The following is a description of a gene set: Human Gene Set: GOBP_NEGATIVE_REGULATION_OF_VERY_LOW_DENSITY_LIPOPROTEIN_PARTICLE_REMODELING Any process that decreases the rate, frequency or extent of very-low-density lipoprotein particle remodeling. Very-low-density lipoprotein particle remodeling is the acquisition, loss or modification of a protein or lipid within a very-low-density lipoprotein particle, including the hydrolysis of triglyceride by hepatic lipase or lipoprotein lipase and the subsequent loss of free fatty acid. species: Homo sapiens, and this is the list of marker genes: APOA2, ANGPTL3, NR1H4, APOC3, APOA1 (apolipoprotein A1), ANGPTL4